Given this list of marker genes CUX1, ZBTB20, SMARCA2, CDC42SE1, NCKAP5, MYH10, SPARCL1, HIF1A (NCBI Gene Id 3091), KBTBD8, CBX3, OCRL, SP110, CLXN, SLC19A4P, ADAMTS5 (NCBI Gene Id 11096), CRLF3, SCUBE2, MLIP, CA3, C5, CETN1, NFE2L2, POU4F1, QPCT, ZNF407, IL6ST, DNER, SNPH, GLUD1, MAML3, FYN, PKP4, RIT1, RUNX3, MORF4, IKZF5, SMPX, NR4A3, PHOX2B, CREBZF, NFIB, TTC12, CDKL1, ARRDC4, LRP8, DMP1, FGF11, NSMCE3, PEX1, PSMD1, MDK (midkine), HNRNPL, AMTN, DCANP1, MSX2, RIPK4, DNMT3B, WNT4, CNOT6L, ACADSB, LUC7L, G0S2, PTK2, NHSL2, KDELR2, FGF16, PPM1B, LCOR, DPH5, NUAK2, IRF2, SYTL2, PCF11, ARL6IP1, CYP26B1, ASF1A, PACSIN3, SLC8A3, TENM3-AS1, MIER3, GARS1, LRR1, OLFM4, FGFBP3 (NCBI Gene Id 143282), ARX (aristaless related homeobox), SSMEM1 (NCBI Gene Id 136263), UBE4B, CDK6, ROR1, CADM2, TNFRSF19, ATP5MC1, CHRNA2, SLC22A2, DSG1, PNRC2, DUSP10, GRM8, WFIKKN2, CCL22, KLHL5, GPR183, BTAF1, WIPF1, HECA, CEP135, LMX1A, PAK1IP1, ZFP36L1, EIF4EBP3, GPM6A, CAMK4, STC1, POLR3GL, SPOPL, SH3BGRL2, ZPBP2, CTAGE4, EFL1, TYRO3, BTBD3, NSRP1, C1orf43, FBXL14, PLA2G7, PTGS2, GJA3, RGSL1, HDX, SLITRK6, MAN1A1, COQ8B, MECP2, GMPR2, GPD1 (glycerol-3-phosphate dehydrogenase 1), SPTAN1, LINC00310, CDK19, NDST4, KIF3B, SLITRK5, DMD, HDAC9, PAX2, GSC, FAM89B, KIF23, NEK6, KRTAP15-1, RGS18, ZIC1, C1orf21, VAMP3, POU3F4 (POU class 3 homeobox 4), MTMR3, EIF4EBP1, CCL8, VPS45, TGIF1, MED30, SLITRK2, HSD11B1, STMN2, ITGB1BP2, HOXA4, FGF20, PLEKHS1, AMBN, C1QTNF7, IL20, HOXC11, NRAS, FN1, ARK2N, VN1R3, SNCAIP, EMP1, ZFHX4, SPATA7, LIX1, OR6C3, LUC7L2, HOXA3, LHFPL6, TCEA1 (NCBI Gene Id 7865), HIGD1A, GGNBP2, DACH1, ACSBG1, PAX6, ZBTB18, CAPS, ELOA, RASA1, P2RY12, CBX4, CAPN6, HJV, APC, SEPHS1, PAX3, ROBO1, NBEA, RALY, MTX2, JARID2, YRDC, C11orf52, NRK, DENND1B, GPR88, RGS13, OGN (NCBI Gene Id 4969), CCNA2, PDK4, CSN2, SOX2, PRKCE, LIN54, DNAJB4, CFH, B3GALT2, TREX2, EHD1, PSIP1, SOBP, GDPD1, MNAT1 (MNAT1 component of CDK activating kinase), ADAMTSL1, FAM91A1, PPP2R2A, IDH3G, ENTPD1, FOXP3, FOXG1, HOXA9, SKIDA1, SAMD7, HNRNPA2B1, SPAG17 (sperm associated antigen 17), CNTN6, TOMM20, GRID2, PITX2, BARHL2, SYNPR, CREM, RGS12, COBLL1, VEGFD, ERRFI1, ASB7, SCN8A, CCDC91, VSIG2, MAX, PAPPA, NSUN5P1, CSNK2A1, OPN5, CRYGD, CNMD, SERTAD4, GPER1, SORBS1 (NCBI Gene Id 80057), GIT1, KRT25, ASPA, LMNA, RORA, USP2, EVI5L, DAAM1, ZNF547, GPR22 (G protein-coupled receptor 22), SLC9C2, P2RY1, PTHLH, TLL2, SLC5A8, SQLE, CSMD3, HOXA2, OMG, DKK1, PELI2, GADD45G, LRRTM4, MYT1, HTATSF1, ULK2, ST18, GPM6B (NCBI Gene Id 2824), SLC4A5, WNT8B, ATP8B1, WWP2, ARHGDIB, NCALD, FST, EN1, RHOBTB1, ADAMTS19, PIPOX, MBD5, GOLM2, PRUNE2, MOAP1, RUNX1T1 (RUNX1 partner transcriptional co-repressor 1), MCTS1 (NCBI Gene Id 28985), LPO (NCBI Gene Id 4025), CBX8 (chromobox 8), SMTNL2, PRL, FRY, PPP4R3B, NSD3, TRERF1, ZNF8, ZBTB10, MECOM, TCF4, TMPRSS11A, APLN, IL23A, PURG, ITGA1, PRPF4 (NCBI Gene Id 9128), LOX, ATP5MC2, SLC1A3, ADAM11, RNF17, PRDM16, GPRIN3 (GPRIN family member 3), DLGAP4, ETHE1, C2CD2, TRMT10A, CNTF, MED14, WNT6, NEUROD6, NOTCH2NLA, NPTX2, IL34, ANKRD17, RPS6KB1, ADGRG4, CRYGS (NCBI Gene Id 1427), SLC25A13, CCM2, MID1, MLLT10, LDB2, IGF1, APEX2, FGF13, SHC3, BHLHE22, HOXA13, CDC42EP3, STC2, INPP1, NDFIP1, CEP97, USP34, TUBD1, RFX3, TEAD1, ARMH3, FGF10, NHLH1, CLEC5A, CPNE1, KRT8P41, STMN1, PCDHGC3, FABP4, ARL4C, DLG2, RGS8, PCSK2, ALDH1A2, AP1G1, SHLD2, SLC6A14, PTPRD, ARHGAP44, CD40LG, GIGYF2, FOS, CYP7A1, HMGA2, NAV3, FMNL3 (NCBI Gene Id 91010), IMPDH1, SBSPON, MPC2, TP63, CHD2, C6orf62, CHML, SPOCK2, FBXW7, JAZF1 (JAZF zinc finger 1), MEF2C, LMO3, GRWD1, GUCA1A, EXOC6, ZFHX3 (NCBI Gene Id 463), HEXIM2, VIT, LINC01559, GARIN1B, HIVEP3, CPS1, RNF43, DYRK1A, TMEM47, TACR3, RAB40A, ITPKC, SHISA6 (shisa family member 6), CA11, FSIP2, RPIA, FOXP2, ADAMTS20, CDH23, RBM48, OGT, SEMA3A, ADRA1A, CARMIL1, PRKAG1, SRPK2, QRFP, SRSF8, ZNF385B, GABRB1, SCAI, DCLK1, NNMT, ACE2, BRD3, NIBAN1, RAD1, IRF8 (interferon regulatory factor 8), UBL4A, ARMCX6, GNB3, RORB, ENAM, SOX5, R3HDM2, PUM3, FBXL19-AS1, WNT2B, LBX2-AS1 (NCBI Gene Id 151534), CFTR, SNTG1, MAS1L, RAP2C, EHD4, MCMBP, LUC7L3 (NCBI Gene Id 51747), H3-3A, BEST3, HOXD3, ELAVL2, TMTC2, TCP11L2, NEDD4 (NEDD4 E3 ubiquitin protein ligase), BEND6 (NCBI Gene Id 221336), ELAVL4, ASB4, EED, ZBTB26, NEUROD2, P2RY13, CREB1, GGN, CTNNAL1, EIF4ENIF1, MNT, RRAGA, SLC9B1, TULP4, ARPP21, OTOS, HDGF, WT1-AS, BCL11B, ZIC4, CHD6, ARHGAP21, FBXL21P, RXFP2, OTOGL, ESM1, GARIN6, NR2E1, MAT1A, CDC26, PGM2L1 (phosphoglucomutase 2 like 1), NRP1, PELO, BEND4, ANKRD28, MITF, MAEL, PAX9, KLF14, KCNK10, SLC24A5, ADGRF3, EHMT1, FBLN5, MAF, BIRC6, KAT6A, NSUN5P2, MYL1, SLC35D1, CCAR1, GOLPH3L, SLC4A10, ZNRD2, RERE, RAB33A, PRKAB2, PPP2R5E, PLCL1, VPS41, CRABP2, WDR17 (NCBI Gene Id 267003), DUSP6, DZANK1, MTHFD2, LY6G5B, AGFG2, RCAN1, HOXB9, ZNF423, LRTM1, SOX6, ALX1, SSR4, DCLRE1A, TFAP2D, SH3BP4, ZNF516-DT, STARD8, KRTAP20-1, KPNA6, NEDD8, PFKFB1, MIEN1, RLIM, OGG1, MIR137HG (NCBI Gene Id 400765), TSHZ3, WIPI1, HPN, MN1, C1orf122, HTR3B, TMEM147, LRRN2, ANKRD11, CTDSPL2, UBXN1, SSPN, NUP54, GMDS, OPCML, TAFA1, PURA, GLUD2, CACNA1S, GLDN, MCF2, C8B, DNAJB12, PCDH10, FZD10 (frizzled class receptor 10), BUB3, KCNJ1, IGFBP5, GPR3, SGMS2, PDS5A, UPRT, TIGD3, SIAH3, FAM13B, PHF21A, ANKRD35, HAPLN1, LINC00303, REL, TENM1, PDXDC2P-NPIPB14P, GATA2, UPF2, NEIL3, EFCAB3, PKN1, CHCHD1 (coiled-coil-helix-coiled-coil-helix domain containing 1), ZPR1, TAS2R38, AP1G2, COPS5, TUG1, UCHL3 (NCBI Gene Id 7347), SCN7A, KBTBD12, PROSER1, NHLRC2, LHFPL1, KLF6, SLC38A6, MLLT11, HOXC10, here is a description of the gene set: Genes having at least one occurrence of the highly conserved motif M174 WTGAAAT in the regions spanning 4 kb centered on their transcription starting sites. The motif does not match any known transcription factor binding site. studied in species Homo sapiens Comprehensive identification of all functional elements encoded in the human genome is a fundamental need in biomedical research. Here, we present a comparative analysis of the human, mouse, rat and dog genomes to create a systematic catalogue of common regulatory motifs in promoters and 3' untranslated regions (3' UTRs). The promoter analysis yields 174 candidate motifs, including most previously known transcription-factor binding sites and 105 new motifs. The 3'-UTR analysis yields 106 motifs likely to be involved in post-transcriptional regulation. Nearly one-half are associated with microRNAs (miRNAs), leading to the discovery of many new miRNA genes and their likely target genes. Our results suggest that previous estimates of the number of human miRNA genes were low, and that miRNAs regulate at least 20% of human genes. The overall results provide a systematic view of gene regulation in the human, which will be refined as additional mammalian genomes become available. from publication Xie X, Lu J, Kulbokas EJ, Golub TR, Mootha V, Lindblad-Toh K, Lander ES, Kellis M (PMID 15735639) Human Gene Set: WTGAAAT_UNKNOWN